The following is a description of a gene set: from publication Xie X, Lu J, Kulbokas EJ, Golub TR, Mootha V, Lindblad-Toh K, Lander ES, Kellis M (PMID 15735639) species: Homo sapiens Comprehensive identification of all functional elements encoded in the human genome is a fundamental need in biomedical research. Here, we present a comparative analysis of the human, mouse, rat and dog genomes to create a systematic catalogue of common regulatory motifs in promoters and 3' untranslated regions (3' UTRs). The promoter analysis yields 174 candidate motifs, including most previously known transcription-factor binding sites and 105 new motifs. The 3'-UTR analysis yields 106 motifs likely to be involved in post-transcriptional regulation. Nearly one-half are associated with microRNAs (miRNAs), leading to the discovery of many new miRNA genes and their likely target genes. Our results suggest that previous estimates of the number of human miRNA genes were low, and that miRNAs regulate at least 20% of human genes. The overall results provide a systematic view of gene regulation in the human, which will be refined as additional mammalian genomes become available. Genes having at least one occurrence of the highly conserved motif M133 RYTAAWNNNTGAY in the regions spanning 4 kb centered on their transcription starting sites. The motif does not match any known transcription factor binding site. Human Gene Set: RYTAAWNNNTGAY_UNKNOWN, and this is the list of marker genes: WNT8B, TDRD5, PACSIN3, NCKAP5, PCDH8, NLGN2, HSF2, ZFPM2, SLC23A3, SLC22A6, ELF4 (NCBI Gene Id 2000), SI, FBXW7, GIP, CREB5, GUCA2B, KLF14, FZD6, PCK1, BDNF, SEMA4G, NALCN, SRD5A2, PALS2, SCN2A, TRIM8 (NCBI Gene Id 81603), SLC22A12, KLF9, GDF10, MSS51, GC, TLE3, GPR34, MED26, RNF145, H3-3B, BMX, SHKBP1, CA4, GTPBP1, CDH17, HAO1, LRRFIP2, TP63 (tumor protein p63), H4C3, MAT2A, RARB, COL16A1, BARHL2, SLC22A8, PTH1R, EEF1A2, EGR1, KCNIP2, SULF2, SMARCAL1, GLRA2, NFIL3, KLB, FOXP2, UGT1A1, STMN2, TSPEAR (thrombospondin type laminin G domain and EAR repeats)